The following is a description of a gene set: species: Homo sapiens Catalysis of the reaction: ADP + H2O = AMP + phosphate + H+. Human Gene Set: GOMF_ADP_PHOSPHATASE_ACTIVITY, and this is the list of marker genes: ENTPD1, ENTPD5, SLC25A42, PGP, CANT1, ALPL